Given this list of marker genes Gm15039, Mob4, Lrrc56, Eapp, Nobox, Gm8825, Rpl35a-ps4, Slc6a2, Mir124-2hg, Prtg, Map3k21, Cd1d1, Cacna1d, Or9g20, Kcnma1, Dlx2, Mir688, Pld5, Foxa1, Slc45a1, Hmgb1, Or8g55, Septin14, Ovol2 (NCBI Gene Id 69059), Samsn1, Olig3, Ube2h, Prex1, Celf2, 9130410C08Rik, Chchd7, Gucd1, St6gal1, Mir363, Hoxa10, Lingo4, Six3os1 (SIX homeobox 3, opposite strand 1), Rpl30-ps5, Vmn1r-ps21, Prr5l (proline rich 5 like), Altre (aging liver Treg-expressed non-protein coding RNA), Wnt2, Rax, Jakmip3, 2410017I17Rik, Pierce2, Pou3f3, Gm27239, Mir490, Olfm5, Gm18660, Kpna1, Smug1, Gm9934, Gm18560, Nr1h4, Mitf, Bhlhe22, Zar1, 4930447C04Rik, Gata6, Pax1dt (paired box 1 divergent transcript), Naa20, Ostm1, Tmem236, Atcay, Zeb1os1, Tlx3, Rbm20, Cdkn2a, mt-Cytb, Gm5597, Gm16976, Esr1, Egr2, Gm40123, Gm9947, Zfp800, Cd209e, Chsy1, Kcnt2, Stac, Nr3c1, Bclaf1, Bdp1, Slc11a2, Exoc5, Inpp5d, Pax6, Nkapl, Gm20445, Txndc15, Atrx, Vstm2b, Fam89a, Adamts2, Fbln5, Acp3, She, Epb41l2, A330032B11Rik, 2810025M15Rik, Dlx6os2, Ndufs5-ps, Gm2174, Gm8369, A830031A19Rik, Mir196a-2, Clec2f, Tril, Ncoa1, Phyhip, Foxl2os, Rgs20, Stat4, Mecomos, Mbd5, Ptprz1, Lrrc2, Prss12 (NCBI Gene Id 19142), Gm11789, Tymp, Krit1, Gask1a, Gata3, Depdc1a, Gpr68, Vax1, Pabpc1l, Slc35f4, Jph4, Gm13629, B4galt4, Shc4, Agap1, Nkx2-2os, Kcnq5, Ikzf3 (IKAROS family zinc finger 3), Onecut3, Sfmbt1, Tmem214, Anxa2r2, Evi5, Sell, Gm10222, Gm13261, Poc1b, Esp4, Ccdc30, Rspo1, Ctbp2, Gm32999, U2surp, Phip, 4930426D05Rik, Cntn4, A730056A06Rik, Id2, Akap7, St8sia2, Rnf125, Npas3, Mir92-2, Runx3, Mir124a-1, Prr23a1, Rbpms, Col19a1, Pax1, Palld, Nfatc1, Gm26812, Gsx2, Angptl1, 4930581F22Rik, Dock3, Cdk12, Hmgn2l6, Mir92b, Stc1, Gm26588 (predicted gene, 26588), Pam (NCBI Gene Id 227401), Gm29478, Gm6071 (predicted gene 6071), Eno4, Gm4785, 4930542C12Rik (NCBI Gene Id 67648), Fgf5, Gsg1l2, Ssr2, Cdc14b, Enpp1, Hdnr, Slc6a4, Usp4, Ascl4, Nkx1-2, Gm16464, Oas1c, Lhx9, Eras, Gm2990, Frem3, Apoo, Gyg1, Prkd3, St8sia4, Mapk1ip1, Gm26618, Igf2os, 2010110K18Rik, Me1, Lrfn5, Epc2, Adcy8, Sec61a2, Zfhx4, A430035B10Rik, Zfp429, Tbx18, Klhl5, Shroom3, Gm23644, Misp, Gata4, Klrk1, Meioc, Mir8110, Six6, Pcdha11, Amer2, D030062O11Rik, Ncald, Gm33973, Gad1, Kcnmb4, Gm11536 (NCBI Gene Id 544810), 1700051A21Rik, Neurod1, Upp1, 4930449E01Rik (NCBI Gene Id 74864), Kcnk6, Mlkl, H60b (NCBI Gene Id 667281), Tbx2, Or10a4, D030046N08Rik, Fendrr, Dstn, Phf19, Gm42580, Anxa2r1, Cep162, Atf1-ps, Tesc, Gm17205, Loxl1, Pate2, Or51f1e, Kat14, Tmem275, Plch1, Gm10419, Hand2os1, Gm30270, Tcf7l2, Lrba, Slc6a20a, Ifnlr1, Mospd4, B3gat2, Slc6a17, Degs2, Afdn, Cacna1e, Nrip1 (NCBI Gene Id 77882), Gm4353, Avpr1a, Usp28, Pde6g, Kif14, Kis2, Zfp777, Muc17, As3mt, Gclm, Sh2d4a, Mir10a, Evx1, Nap1l1, Cripto, 1700039I01Rik, Tbc1d8b, Scn9a, Fgfr2, E130102H24Rik, Barx2, Rtraf, Pcdh15, Jph1, Nr5a2, Agbl4, Apbb1ip, Prox1os, Gm13688, Gabrb2, Amz1, Nfasc, Htr1b, Zfp536, Pkp4, Kirrel3, Nsg2, Zfp142, Secisbp2 (SECIS binding protein 2), D630045J12Rik, Trim2, Pwwp3b, Sfmbt2, Kcna4, Cttn, A730094K22Rik, Map3k20, Grm1, Mgarp, Dhrs3, Thsd4, Gm3145 (predicted gene 3145), Eci3, Gm10475, 5730488B01Rik, Lonrf2, Ankrd1, Sgcz, Chn2, Lin28b, Csmd2, Mcf2l, 9630001P10Rik (NCBI Gene Id 319251), Lss, Hoxc9, Vstm2a, Txlng, Dlx1as, Gm23796, Mkx, C230012O17Rik, Mapre3, Zpbp2, Gm20387, Cacnb2, Prdm16os, Rpl10, Hoxc12, Mir99ahg, Adam7, Slc25a23, Hottip, Pfdn4, 2610016A17Rik, Ecel1, Tbx1, Slamf1, Sall3, Cdh13, Gm15853, Hes3, Carhsp1, Gm17068, Kcnj10, Igkj4, Gm26654, Arx, Zdhhc17, Gstt2, Gk, 1700066J03Rik, Tex30, Gm16437, Ank1, Vsx2, 4930593A02Rik, Abcc9, Sfi1, Psd4, Ankrd33b, Gm266, Msi1, Gm5499, Tia1, Hhex, Limch1, Hnf1b, Tfdp2, Slc30a3, Gm13422, Ppfia2, Pde7b, Dlk1, Bhlhe41, Mir1931, Pphln1 (NCBI Gene Id 69779), Zmym4, Lrrc9, St6gal2, Pitx3, Smarcal1, Hmgn2-ps1, Dhx16, A430072P03Rik, BC046401, Gm12628, Dlg4, Pik3ap1, Dspp, Gabra1, Gm17936, Hoxc10, Trmt112, Plk5, Otx2, Slc35d3, Gm26397, Acbd6, Izumo1, Mreg, Gfi1, Ppwd1, Pde8b, Lims1, Pknox2, Gm9767 (predicted gene 9767), Ptgdr, Gripap1, 4930588K23Rik, C030047K22Rik, Mtmr14, Ucp1, 2310009B15Rik, Mef2c, Opcml, 4930586N03Rik, Tjp2, Tbx5, Atp5mc2, Rgs10, Thra, Lhx1, Cd200, Mir5135, Dll4, Ntf3, Tex14, Frzb, Slc7a10, Swt1, Gm9885, Smad7, Pcdha10, Magi2, 2610307P16Rik, Myb, Ctnna3, Kirrel2, Gm12428, Ocln, Lmo2, Gata3os, Thpo, Ezh1 (enhancer of zeste 1 polycomb repressive complex 2 subunit), Uncx, Gm9929, Il27ra, E2f4, Fastk, Carlr, Tfap2b, Rsrc1, Abcg8, Tbx3, Ptpru, Ccdc141, Hoxa11os, Kif13b, Atoh1, Gm5432, Ebf1, Lrrk2, Hras, Nav3, Gm12313, Scube3, Ciz1, Htra4, Plppr5, Gm7417, Bbs4, Tifa, Gm23389, mt-Nd5, Gm26684, Cass4, Hoxd8, Pcdh10, Gm37047 (predicted gene, 37047), Zfp91, Gm7652, B4galnt2, Dlgap2, Isl1, Plut, Esrp1, Fgfr3, Ooep, Akap13, Vrtn, Lhx2, Tex12, Aasdh, Gm17501, Arpp21, A630072M18Rik, Mast4, Slc30a2, Gm16136, Hpcal4, Onecut1, Eya1, Gm15934, Barx1 (NCBI Gene Id 12022), Snx7 (sorting nexin 7), Fbxo44, Phox2b, Zfp202, Hebp1, Tgm3, Angptl4, Kcnh4, 4933414I15Rik, Plekha8, Mir6236, Pdrg1, Gm26973, Reg4, Ednrb, Stard13, 1700039M15Rik, Hs3st3b1, Adgra2, Foxf2, Virma, Tbr1, 2600014E21Rik, Gpr149, Clrn1, Kctd8, Gm336, 1700092K14Rik, 4930512H18Rik, Tbx15, Ppp3r1, Rgs16, Cped1, Pax3, Epha3, Bmper, Sgms2, Arid3c, Scgb2b26, Msx1, Adcyap1, Hmx2, Hoxd11, Gm16958, Egr3, Rbm45 (NCBI Gene Id 338539), Sall4, Zfpm2, Rln3 (relaxin 3), Zic4, Cbr4, Tmem266, Astn1, Adgrl3, Tmco4, Mir128-2, Rpl15-ps2, Ppp1r3g, Slit3, Fam169a, Car10, Egfr, Gm30835, Gm4221, Ntng1, Gm14858, Foxn4, Pigb, Or51b4, Foxi3, Six1, Scn1a, Foxf1, Tle2, Mir9-1, Lhx5as1, Fgf9, Cpne2 (copine II), Gm17767, Npdc1, Islr2, Azi2, Tlx1 (T cell leukemia, homeobox 1), Pcdha2, Lsm2, Gm10561 (NCBI Gene Id 632923), Gm24680, Nostrin, Mir196b, Chd4, Gatm, Sgk1, Gm16731, Gm7832, Neurog2, Erich5, Gm5627, Mtcl3, Gm15018, Dpf3, Tlx2, Nrg4, Igf2bp1, Phactr1, Rtl9, Wt1, Rgs7bp, Nkx2-4, T, Pramel15, Abca4, Nudt19, Hes1 (NCBI Gene Id 15205), Sox2ot, Nkx2-9, Snora24, mt-Td, Fbn1, Gm33366, Spindoc, Mir124a-2, Erg, Gm6556, Acadsb, Dkkl1, Gm5124, Gm13429, Oaz1-ps, B3galnt1, Foxp1, Immt, Zcwpw2, Vmn2r-ps111, Folr1, Nkx2-1, Nuak2, Gm28876, Nr3c2, Gm12688, Rcan2, Frat1, Fev, Hoxb4, Smad9, Sulf2, Phkg1, Gm13584, Orai3, Trp53i13, Chst2, Proscos, Gm8019, Slc1a1, Gm26688, Edil3, Entpd1, Shox2, Or1j10, 2310010J17Rik, Tmem196, Aaas, Hs3st3a1, A430027H14Rik, Gm18829 (NCBI Gene Id 100417792), Hmx1, H2-Q6, Gm31925, Fermt1, Gm12446, Morf4l1, Pde8a, Zfp770, Kctd16, Mterf3, Yeats2, Hey1 (hairy/enhancer-of-split related with YRPW motif 1), Gm13283, Lsamp, 4930599N23Rik, Lbx1, Gm10461, Ammecr1, Nefl, Igkv17-134, Pou3f2, Hexa, Sox7, Slc7a8, Redrum, Gm14857, Nkx2-3, Nfe2, Tmed3, G630016G05Rik, Mir375, Igsf11, Foxc1, Herc3, Rasgrf1, Nkx6-2, Rn7s6, Lrrc3c, Ccdc38, Tdrd1, Gpr50, Cdc42bpa, Gm9913, Gm10244, Kcnc2, Map6, Lamp5, Olfr1401-ps1, Sec61g, Cnih4, Gm4409, Tardbp, Pip5k1b, Gm11560 (NCBI Gene Id 670554), Kazald1, Lysmd2, Trim17, Hoxc8, D130058E05Rik, Neurod2, Fitm2 (fat storage-inducing transmembrane protein 2), Crnde, Plcb2, Zfp872, Gm4895, Gm9945, Dnmt3l, Gm12241, mt-Tp, Gm26129, Gm11762, 1600029O15Rik, Clvs2, Prdm12, Spag6, Runx1t1, Uhmk1 (U2AF homology motif (UHM) kinase 1), Meis1, Zpr1, Nbea, Lcp1, Zfp951, C1ql2, Foxd2os (NCBI Gene Id 320458), Pantr1, Hoxb7, Pdpk1 (NCBI Gene Id 18607), Hoxa13 (homeobox A13), Osr2 (NCBI Gene Id 93693), Csnk2a2ip (casein kinase 2, alpha prime interacting protein), Kcnq4, Tmem215, Alg11, Cldn7, Smt3h2-ps4, Gm5091, Hs3st5, Uba2, Or51k7, Pdx1, Fgfr1, Neto1, Rimklb, Zbed3, Nucb1, Gm4321, C130093G08Rik, Aox4 (aldehyde oxidase 4), A830082K12Rik, Vwa5b2, Paqr9, Tns3, Col4a1, Ccna1, Sox6, Popdc3, 9530036O11Rik, Sox9, Dhcr7, Gm15222, Irx6, Rnase4, Slitrk5, Prdm16, Pou4f3, Nr2e1, Rtn1, Mir34b, 2410137M14Rik, Gm26704, Npbwr1, Psmd5, Trim71, Mir10b, Mmp14, Mif4gd, Fchsd1, Nr2f1, Slc9a2, Bcat1, Evx1os, Gm26748, Gm2670, Drgx, Cep135, Slc6a5, Bub3, Gm9791, Sos2, Sp8, B230323A14Rik, Nup160, St6galnac6, Fyn, Mycbp, Gm22079, Gm10129, Nkx2-2, Gm12676, Ppp1r42, Gm20554, Mest, Atxn7l1, Gm12268, Trp73, Elavl3, Sphk1, Myg1, Rfx4, Cbx3-ps6, Tfap2c, Cyp4b1-ps1, Pdlim3, Foxb2, Prok2, Pou4f1, Cald1 (caldesmon 1), Mtx1, Rps4l-ps, Ankrd34b, Lrrc66, Gm43522, Wipf1 (WAS/WASL interacting protein family, member 1), Arid3b, Pole4, Gckr, Sqor (NCBI Gene Id 75837), Bmal1, Npr2, Gm10748 (NCBI Gene Id 100038710), Mcub, Wnk2, Gm13239, Rab12, Il12rb2, Ldha, Foxa2, 4932441J04Rik, Zyg11a, Mia2, Trpm2, 9530018H14Rik, Ndst3, 4932412D23Rik, 1500012K07Rik, Gm26994, Hoxd12, Mllt3, Mir196a-1, Klhl14, Mid1, Rgs6, Wnt7b (wingless-type MMTV integration site family, member 7B), Gm12462, Prss16, Slc1a3, Slc43a1, Ankrd60, Bcl2, Slc16a9, Pals2, Gsta3, Ebf3, Gm16984, Tmem163, Lsp1, Wnt5a, Adam34l, Lhx4, Nexn, Tmtc1 (NCBI Gene Id 387314), Parp12, Brca2, Nek5, Gad2, Gch1, Pde4d, Gata2, Map6d1, Gm53, Snf8, Trim34a, Sp6, Acin1, Grb10, Fgf13, Ppm1h, Dchs1, Cav1, Nrn1, Gm16505, Tcte2, Ddah1, Paupar, Lhx3, Cfap276, Gm7113, Ptprr, 9530059O14Rik, Hand2, Eya4, Tmem178, Greb1, Has2, AI606473, Egfem1, Sox17, Gm21168, Mettl17, B3gnt5, Tmem201, Gtf2i, Insrr, Esr2, Pole2, Gabra2, Gm12458, Lef1, Wif1, Gm7341, Slc17a2, Cdc25c, Kbtbd11, Sccpdh, Pde4dip, Rtl8b, Gm4852, Pbdc1, Itih3, H2-T5, Trpc5, Fat4, Nkd1, Arhgap18, Gm11849, Tlcd4, Ppp2r2d (NCBI Gene Id 67813), Snx10, St3gal6, Speg, Ihh, Gm15050, Bnc1, Csmd3, Cyp2s1, Rps6ka6 (NCBI Gene Id 67071, ribosomal protein S6 kinase polypeptide 6), Usp49, Prpf38b, Cdkn2c, E030030I06Rik, Zmynd11, Sema3a, Alox15, Gm9260, Traj51, Irag1 (inositol 1,4,5-triphosphate receptor associated 1), Etl4, Mmp16 (NCBI Gene Id 56518), Slc26a4, Pparg, Gm9924, Hivep3, Hoxa9, Fzd7, Galnt7, Trim28, Gm10254, Tmcc3, Gin1, Stk32a, Maf, Slitrk4, 1700019A02Rik, Cd151, Gm26705, Gm7291, Nr6a1os (NCBI Gene Id 102641575), Lhx6, Bcar3 (NCBI Gene Id 99553), Gsx1, Gm24067, Entrep1, 4930442P19Rik, Srgn, A730035I17Rik, Nav2, Hoxc5, 3110004A20Rik, Pgs1 (phosphatidylglycerophosphate synthase 1), A430110L20Rik, Gm14634, Zbtb8b, Pcdhgc3, AW047730, Gm12707, B3galt1, Dock7, 1700096K18Rik, Fam24b (NCBI Gene Id 69318), Zfp706, Hoxa11, Flt4, Mab21l1, Zic2, Gpr89, Zfp133-ps, 4930557F10Rik (RIKEN cDNA 4930557F10 gene), Prdm6 (NCBI Gene Id 225518), Trmt9b, Tbcel, Hoxaas2, A130023I24Rik, Dlx5, Syt10, Sptbn1, Ankrd24, Zeb2, Acot4 (acyl-CoA thioesterase 4), Epdr1, Hpgd, Gcn1, Gm24764, Zic5, Abcb1a, Rc3h1, Gas2l2, Csmd1, Polr3e, Lrmda, Lrrc7, Crem, Fam110c, Sybu, Tpr, Pax7, Cpne8, Shank2, Tmc5, Epha10, 5730585A16Rik, Cpe, Dock10, Ttc39b, Gm14204, Mpz (NCBI Gene Id 17528), Abhd13, Lrp1b, Zfp804a, Zfp395, Gcnt2, A330074H02Rik (NCBI Gene Id 402758), Gm16551, 0610040J01Rik, Etv2, Adam22, Nkain2, Slco6c1, Spata3, Pitx1, Bcl11b, Gm15564, mt-Te, Nabp1, Slc18b1, Foxc2, Gm26923, Tfrc, Asph, Tm2d2, Rasa3, Mal, Hilpda, Lad1, Sv2b, Wdr87-ps, Kcnj8, Sri, Pcdhga10, Lysmd3, Pacsin3, Tcf21 (NCBI Gene Id 21412), Galnt10, Vcam1, Gm17473, Ccnh, Ino80, mt-Nd6, Nasp, Msrb3, Tor3a, Ncoa2, Nr2f2, Dmrt2, 4930594M22Rik, Prkce, Gm14964, Adamts6, Six2, Lhx1os, Arhgef2, Slain1, Lamtor5, Pcdha8, Prdx5, Adra1b, Mms19, Gm16209, Lpl, Mpzl1, En1, Gm23435, mt-Tc, Rnd3, Tcf4, Tsr1, Usp35, Pcdha4b, Vax2os, Tmem242, Satb2, Gm40304, Prex2, Naa35, Nfia (NCBI Gene Id 68838), Prrt1b, Hoxb6, Mir9-2hg, Tox, Pantr2, Dcc, Dgki, Mppe1, Helt, Esrrg, Anks1b, Scmh1, Map3k5, Coch, Prdm13, Vmn1r45 (vomeronasal 1 receptor 45), Gm20646, Mast1, Gm9916, Sbf2 (SET binding factor 2), Rbp4, Rnu1b2, Vmn1r30, Ddx59, Htra3, Mecom, 2610316D01Rik, Asns, Gsap, Pcolce2, Tcf7, Pcsk6, Oasl1 (NCBI Gene Id 231655), St3gal4, Pax2 (NCBI Gene Id 207129), Hoxd3, Greb1l, Irs4, Gm23123, Rspo3, mt-Ty, 4833413E03Rik, Cables1, Or1e23, Gm35065, Gm13749, Igf2, Etv1, Otp, 9230109A22Rik, Pcdh7, Hnrnpll, Alx1, Slc32a1, Gm15482, Trps1, Hoxb8, E2f1, Bcan, H2-T7, Gpr85, Vps4a, Ntrk3, Nbeal1, Gm23737, Hey2, Fam131a, Htr7, Ripply3, Dock8, Coq9, Zfp608, Dop1a, Ttc14 (NCBI Gene Id 99698), C130021I20Rik, Calcb (calcitonin-related polypeptide, beta), Sypl2, Phospho1, Gm14261, 2610035F20Rik, Ankrd63, Duxf2, Rnf220, Tyrobp, Rhbg, Tcea3, Fbp1, Osr1, Pcdh9, Ppp6r3, Hoxa3, Lig4, AI504432, Eef2k, Trpc4, Sowahd, Pgpep1l, Gm21221, Minar1, Dnaaf1, Tfap2a, Trit1, Nr4a3, Or6z3, n-R5s1, Hoxb5, 2900079G21Rik, Rnf144b, 1700030C12Rik, Gm16401, Nova1 (NCBI Gene Id 664883), Mpped2 (metallophosphoesterase domain containing 2), Grip1, Grm6, Fbxo30, Shisa3, Cfap65, Frmd4a, Fbll1, Gm2622, Supt3, Mir9-2, Stag3, Cabp1, Get4, Crmp1, Kcnh3, Kcnip4, 4933402J10Rik, Lrrc63 (NCBI Gene Id 70859), Gm10157, Slc22a27, Col4a3, Mmp25, Igkj3, Gm2464, Prob1, Wnt11, C2cd4a, Nlgn1, Mrpl9, Raxos1, Magel2, Gja3, Adgrg6, Picalm, Sec23a, Zfp423, Nkx2-5, Dbpht2, Mc4r, Irx2, Otos, 9130024F11Rik, Irx3os, Ntn4, Rtl4, Cic, Cdh11, Olig2, Hoxb2, Cgas, Cnpy1, Isl2, Meis2, Gm5989, Gm6651, Onecut2, Ncam2, Hoxd13, Pom121l2, 1700063I16Rik, 3110039M20Rik, Chst9, Kcnj4, Cbln2, Man1a2, Gfra1, Cttnbp2, Pax5, Col4a4, Rgs18, Zswim5, Hecw2, Cerkl, Bmp7, Ccnl1, Zfp57, Prkcz, Mapk4, Thnsl1, Enkur, Lmx1b, Tmub2, Bag2, Kif5c, Tox2, Clic5, Rpp25, Rgs3, Gm4857, Sp5, Iffo1, Gm15946, Tshz2, Traj1, Pou4f2, Gulp1, Fgfbp3, Sarm1, Tnfrsf9, Plcxd3, Fblim1, Ganc, Arhgef15, Yap1, Esam, Med14, Kcnmb4os2, Gm11249 (predicted gene 11249), Lrrtm3, Rcbtb2, Leng9, Pcdha4, Gm12623, Gm14862, Hoxd4, Slc10a4, Nploc4, Ms4a12, Pik3r6, Coro6, Nisch, D430041D05Rik, Syt12, Rgs22, Gipc2, Snd1, Gm15786, Ewsr1, Rbks (NCBI Gene Id 71336), 4632427E13Rik, Ptx3, Abcc3, Gm9134, Ap1s1, Krtap19-9a, Cyp4f14, Kcnj16, mt-Co2, Gja5, Pcdhga8, Lhx8, Glud1, Nans, Anp32a, Barhl1, Syt16, Cyp2j13, Stau2, Cxxc4, Tbx4, Rint1, Mir7044, Tsga13, mt-Tt, Slc4a10, Mir449b, Sall1, Rsbn1l, Plekhd1os, Ndnf, Zcwpw1, Traj45, Foxl2, Grik2, Gm20467, Ptpn5, Cdh12, Celf4, Hoxb13, Lmx1a, Pi4k2b, Gbx2, Rpl38, Ptpn22, Foxg1, Rasef (RAS and EF hand domain containing), Zbtb20, Fah, Gm10356, Spon1, Phactr2, Gjc1, Exph5, Gm8676, Gm26629, Npas2, Ldb2, Sgip1, Pcdha9, Ighv1-43, 9630013D21Rik, Kctd1, Gm13425, Pgap6, Scube2, Grid2, Mir672, Slc16a6, Gm17031, Arih1, Csrnp3, Zfp623, Galnt17, Stx3, Syndig1, Far1, Cry1, Fam169b, Evx2 (NCBI Gene Id 14029), Lmo3, Zmat1, Cntn3, Atf3, Gm12576, Gpr12, Tnrc18, Raet1e, Adamts8, Gm27032, Gm34379, Rwdd2a, 1700063K16Rik, Gm4524, Nptx1, Runx1 (runt related transcription factor 1), Wrap73, Zfyve16, Fndc11, Prkacb, Gm3764, Prox1, Slc7a15, Robo4, Spata18, Foxl1, Platr7, Sh3gl2, Sall2, Usp44, Hyls1, Gm4117, Nhlrc3, Vwc2, Cdx2, Upb1, Tgfb2, Mir124a-3, C1qtnf4, Gm24440, Eomes, Farsb, Gnas, Gm13736 (predicted gene 13736), Pgd (phosphogluconate dehydrogenase), Dpy19l4, Rspo2, Skida1, Dlg2, Nebl, Sis, 9330158H04Rik, Otx1, Tbrg4, Nkx2-6, Nkx3-2, Hoxa7, L1td1, Pdgfd, Cracd, Stra6 (NCBI Gene Id 20897), Ikzf1, Pstpip2 (proline-serine-threonine phosphatase-interacting protein 2), Sycp2l, Gm11999, Sardh, Dpp10, Gm18367, Gm12063 (predicted gene 12063), Igkj2, Zfhx3, Mir615, Mgst3, C9 (complement component 9), Mir3078, Hunk, H2ac25, Klhdc4, 1700108N11Rik (RIKEN cDNA 1700108N11 gene), Vwa3b, Dab2, Pax9, Gm13652, Matk, Nrxn1, Sim1, Trim14 (tripartite motif-containing 14), Tmeff2, Ina, Art3, Dlat, Poln, Tshz1, Ap1s2, Fkbp9, Sstr1, Hmgxb3, Marchf1, Gm12606, Ccr9, Pin1, A230052G05Rik, Gchfr, Gm9889, Gm8213, Gm15295, Gm9955, n-R5s211, Slc24a4, Arsg, Mtfr1l, Ccdc169, Esx1 (extraembryonic, spermatogenesis, homeobox 1), Mmp9 (NCBI Gene Id 99431), Radx, Vax2, Grtp1, Gm19026, Trim36, Inpp1 (NCBI Gene Id 98626), Nr2f6, Aqp9, C3ar1, Itga9, Zwint, Trim67, Cfap52, Wiz, Ppp3cb, Car3, Nol4, Gm24296, Cdh10, Nell1, Esd, Plekha2, Timp4, Kcna1, Tal1, Ltb4r1, Abca16, Fndc3c1, Socs2, Zdbf2, Igf1, Plagl1, Pigz, Pcdh8, Rps19-ps6, Adra1a, Mansc1 (MANSC domain containing 1), Plb1, Robo3, Barhl2, Zar1-ps, Macroh2a2, Cdk8, Eef1d, n-R5s88, Gm12757, Emx2 (empty spiracles homeobox 2), Lclat1, Nr4a2, Dusp7, Plekhg3, Thsd7a, Gm5763, Flrt3, Nkx1-1, Hoxc11, 0610043K17Rik, Chn1, Gad1os, Mfsd4b2, Grin2a, Thsd7b, Bambi, 9430021M05Rik, Lbx2, Zeb1, Phc1, Tgif1, Gm14601, Mdk, Gm15042, Nfs1, E330040D14Rik, Gm15833, Skor1, Prdm1, Acaca, Zfp946, 2310015D24Rik, Pitpnc1, Pappa, Elapor1, Vdac2 (voltage-dependent anion channel 2), Them7, Cbln1, Gm9359, Prlr, Gm15821, Sim2, Pfkp, Ear-ps4, Meox2, Reno1, Nup42, Npy, Mir1901 (microRNA 1901), Cnnm4, Prdm15, Mllt10, Lemd1, Haglr, Cd1d2, Sp3, Rbm43, Fgf4, Bahcc1, Galr2, Ltk, Six3, Dlx6os1, Shisa6, Tm4sf5, Dsc3, D430036J16Rik, Magohb (mago homolog B, exon junction complex core component), Amd2 (NCBI Gene Id 11703), Slc35a3, Igf2bp3, Nipa1, 2700033N17Rik, Nt5e, Cog3, Lep, Men1, Satb1, Dleu2, Otx2os1, Megf8, Tnfaip6, Gm12101, Mir7673, Miat, Rasal2, Gm26871, Hoxd9, Sel1l3, Gm8357, Tlk2, B3gnt7, Klf14, Gm14207, Lgi1, Tbc1d14, Cpeb3, Ripk4, Slc39a8, Commd3, Trpm5, Il17rc, Sbspon, Gm6659, Mpc1, St18, Nrg1, Tmem217rt, Gm13674, Dlx3, Dlx1, Unc5c, Gm28523, 1700025A08Rik, Gm6069, Abca6, Cdh6, Ddr2, Rep15, Pnkp, Asb3, Olfm1, Brinp3, Myc, Gm9996, Spatc1, Stk32b, Gm29246, 4930477E14Rik, Pop4, Cc2d1b (coiled-coil and C2 domain containing 1B), Unc80, Lamc2, Gm12993, Zeb2os, Gata3un, Unc45bos, Lrrtm4, Gm10837, Auts2 (autism susceptibility candidate 2), Gm17969, Rpl31-ps4, 1700017M07Rik, Slc27a2, Dhx36, Gm14903, Abhd6, Mir3093, Wnt6, Dclk2, Gm25137, Gpr15lg, 9030622O22Rik, Spef2, Tmem47, Atp6v1c2, Tlr2, Mtmr7, Zic3, Mir449a, Ctxnd1 (cortexin domain containing 1), Or5w16, Exoc3l, Gm12612, Hand1, Pcsk5, Traj46, Neu2, Itgb1, Prdm14, Gm12056, Pard3, Or51a10, mt-Ts2, Elfn2, Gm13435, Pou2f2, Elk3, Ece2, Ptpn21, mt-Th, Mras (muscle and microspikes RAS), Gata6os, Npy5r, Ripply2 (ripply transcriptional repressor 2), Foxd1, Aldh1a3, Hmx3, Podxl, Gm13179, Lats2, Lactb2, Prdm8 (NCBI Gene Id 77630), Fam90a1b, Tpbg, Pcdh1, Foxd2, Lrrtm1, Tbx3os1, Gm16341 (predicted gene 16341), Gm6277, Sympk, 9330154J02Rik, Ang, Ppp1r1c, 1600023N17Rik, Mir9-3hg, Irf8, Nudt16, Fgf14, Trim29, Runx2, Gm10645, Nr5a1, Mptx1, Pdgfra, Gm9979, Alx3, Jam2, Slc9a8, Gm29514, Glcci1, 4833422C13Rik, Mepce, Papolb, Rheb, St6galnac2, Mir137, Ceacam9, Mab21l2, 9130019P16Rik, Or2y1, Ica1l, 8430419K02Rik, Cobl (cordon-bleu WH2 repeat), Slc7a7, Irf2bpl, Vsig10, Gm13121, Tmem88 (NCBI Gene Id 67020), Rbm19, Nsmaf, Car14, Acan, Lncpint, Abca13, Trpm8, Gsc2, Fzd6, Emx1, Nbl1, Gm18734, Myo5c, Prune1, Ebf2, Mdga1, Cldn3, Zfp735, Ahsa2, Gm7389, Sp9, Mir670hg, Ermp1, Msx2, Cep95, Ube2e2, Cited1, Gm25289, Mir124a-1hg, Shbg, Zfp975, Lrriq1, Atf6, Gm7862, Itgb2l, Ythdc2, Sgk3, Rasl10a, Scin, Elovl5, Tenm2, Gm9157, Cd47, Tac1, Sobp, Gm13344, Tdrd5, Fam171b, Hoxc6, Gfra3, Chrm2, Ipo11, Ppa2, Vmn2r-ps78, Tspan12, Cypt4 (NCBI Gene Id 69323), Ccn1, Gm14108, Gdnf, Ccno, Sema3g, Dok6, Dmrt3, n-R5s194, Hlx, Homer1, Foxa3, Kcns3, Cenpv, Rab15, Gm5067, Arhgef1, Tgds, Rad51ap2, Pax6os1, Or8b44, Hoxd3os1, Fut9, Zic1 (NCBI Gene Id 22771), Pde1a, Rfx3, Bmi1, Gfra2, Mir503hg, P3h1, Gm15807, Hlf, Emx2os, Atp7b, Dnajc6, mt-Tl2, here is a description of the gene set: species: Mus musculus from publication Yevshin I, Sharipov R, Kolmykov S, Kondrakhin Y, Kolpakov F (PMID 30445619) Mouse Gene Set: BMI1_TARGET_GENES Genes containing one or more binding sites for (Bmi1) in their promoter regions (TSS -1000,+100 bp) as identified by GTRD version 20.06 ChIP-seq harmonization.